Given this list of marker genes Efl1, Sbds, Eif6, Xrcc5, D1Pas1, C1qbp, Rpl38, Abt1, Nsun4, Prkdc, Ddx3x, here is a description of the gene set: Mouse Gene Set: GOBP_CYTOSOLIC_RIBOSOME_ASSEMBLY species: Mus musculus The aggregation, arrangement and bonding together of the large and small ribosomal subunits into a functional cytosolic ribosome. Distinct stages of this process take place first in the nucleolus, then in the nucleus and finally in the cytosol.